Given this list of marker genes CAV1 (caveolin 1), AEBP1, TUBB4A, PSMC3, NGLY1, here is a description of the gene set: Lack or loss of the soft tissues between the zygomata and mandible. studied in species Homo sapiens Sunken cheeks Human Gene Set: HP_SUNKEN_CHEEKS